Given this list of marker genes Ptk2, Fyn, Cdc42, Ntn4, here is a description of the gene set: part of: Axon guidance studied in species Mus musculus Reactome Pathway: Netrin-1 signaling This event has been computationally inferred from an event that has been demonstrated in another species.<p>The inference is based on the homology mapping from PANTHER. Briefly, reactions for which all involved PhysicalEntities (in input, output and catalyst) have a mapped orthologue/paralogue (for complexes at least 75% of components must have a mapping) are inferred to the other species. electronically inferred by orthology from the curated human pathway